The following is a description of a gene set: Abnormality of bone mineral density studied in species Homo sapiens This term applies to all changes in bone mineral density which (depending on severity) can be seen on x-rays as a change in density and or structure of the bone. Changes may affect all bones of the organism, just certain bones or only parts of bones and include decreased mineralisation as may be seen in osteoporosis or increased mineralisation and or ossification as in osteopetrosis, exostoses or any kind of atopic calicfications of different origin and distribution. The overall amount of mineralization of the bone-organ can be measured as the amount of matter per cubic centimeter of bones, usually measured by densitometry of the lumbar spine or hip. The measurements are usually reported as g/cm3 or as a Z-score (the number of standard deviations above or below the mean for the patient's age and sex). Note that measurement with this method does not reflect local changes in other bones, and as such might not be correct with regard the hole bone-organ. Human Gene Set: HP_ABNORMALITY_OF_BONE_MINERAL_DENSITY, and this is the list of marker genes: CDKN2B, AP1S2, NAE1, HBB, KCNJ8, CLCN5, NGLY1, GBA1, NFATC2, HAMP, AARS1, TMEM67, IRF5, OTX2, ATP7A, EHHADH, MPLKIP, SLC29A3, ADAMTS2 (ADAM metallopeptidase with thrombospondin type 1 motif 2), GLB1, SLC39A8, IL12RB1, BRAF, AMER1, MLXIPL, FANCD2, RFC2, IGF1, DNAJC21, NAB2, POLR3A, CHD6, LPIN2, SRP19, ALB, PCCA, NSD2, SMAD3, TSPAN12, PALB2, NPM1, TNPO3, PEX12, TNFSF11, DCHS1, IKBKG, EIF2AK3, CTCF, TET2, SNORD116-1, MEG3, CFTR, TRPV6, SPARC, NCF1, SOS1, MRPS22, ESR1, BUD23, HERC2, IL6, LACC1, MDM4, CYP27A1, LZTR1 (NCBI Gene Id 8216), PHEX, RRAS, INVS, RNU7-1, PRKACA, POLR1D, RNF113A, HHAT, LAMB3, GTF2H5, MITF, XYLT2 (NCBI Gene Id 64132), SOX3, DUSP6, FGFR1, CTC1, B3GALT6, FBN1, UBA2, HMOX1, TGFB1, NR0B1 (NCBI Gene Id 8238), FOXA2, CDKN2C, SFRP4, EED, PARN, MMP2, CEP164, TERC, TRPV4, AEBP1, MALT1, TRPS1, GK, SMS, FN1, LRP6, NPR2, HECW2, DDRGK1, TAPT1, FANCF, HGD, POLR1B, TMEM38B, MKRN3, CRIPT, TNFRSF11B, NPHP4, SPIB (NCBI Gene Id 6689), XRCC2, FGFR2, ELN, GNPTAB, STX3, CTDP1, PCCB, SRC, TBL2, COX4I2, SLC26A9, STAT1, SEC23A, PAPPA2, MIF, NPHP1, PTDSS1, CEP290 (NCBI Gene Id 9707), CBS, HLA-DRB1, PTH1R, NAA20, POU1F1, CYP11A1, CEACAM3, TMEM165, NOTCH3, MAP2K1, AXIN1 (NCBI Gene Id 8312), CBFB, GTF2IRD1, RPL10, BRIP1 (BRCA1 interacting helicase 1), HSPG2, LIMK1 (NCBI Gene Id 3984), FAM20C, AP2S1, DKK1, DHCR24, SMPD1, USP48, IFIH1, HRAS, FAM111A, HSD3B7, IQCB1, HSD17B4, SLC34A2, DNAJC30, CDKN1B (NCBI Gene Id 1027), RIN2, IL1RN, MEN1, NDP, SATB2, VCP, HLA-DQA1 (NCBI Gene Id 7946), SYK, PEPD, SEMA4D, PTEN, SOS2, LTBP4, SLC7A7, SPRED2, BANF1, CYP27B1, SETBP1, RBL2, IRX5, DLK1, PSTPIP1, GALT, RNF125, CLPB, WNK1, RASA2, PLEKHM1, TNFSF15, TNNC2, HFE, SMARCD2, HJV, TBCE, SH3PXD2B, POLG, COL1A2, POF1B, NHP2, CAVIN1, CTNNB1, PIGY, EDNRA, TJP2, WNK3, HNRNPH1, NR5A1, PLOD3, RFWD3, FANCE, CCDC141, LIFR, ACP5, VDR, SNRPN, CALCR, FKBP6, TAC3, FGF23, BRCA2, AVP, FSHR, NOP10, TYROBP, ZBTB20, SOST, ITGB4, NHLH2, TGFBR2, SDCCAG8, HTRA1, GATA1, HLA-DQB1, LMX1B, ANOS1, RPL11, MTRR, AIFM1, EBP, SLCO2A1, HGSNAT, MAGEL2, TMEM53, POC1A, WDR19, CREB3L1, B4GALT7, UBE2T, PLEC, CCN6, SCARB2, IFT52, DNA2, CYB5A (cytochrome b5 type A), GFI1, EXT2, NFIX, OSTM1, MAD2L2, PIGG, TREM2, SLC34A3, RIGI, BAAT, IFT56, CTSK, ASXL2, TONSL, ZEB2, SBDS (NCBI Gene Id 89877), RUNX1, MGAT2, SOX5, TCIRG1, DKC1, ESR2, TWNK, ENPP1, LRRK1, BMP15, TBCK, VPS37D, NDUFAF6, FGF17, OFD1, EFL1, FAH, FANCM, NUP107, HESX1, B3GAT3, MTX2, CARS1, OCA2, PPIB, PTPN11, SLC9A6, MAN2B1, ATP6V0A1, SLC17A5, AGXT, G6PC1, POLR3H, DMP1, GJA1, RRM2B, FLRT3, KDM1A, KISS1, FZD4, CSF1R, P4HB (prolyl 4-hydroxylase subunit beta), ERCC2, PDGFRB, KRAS, NDUFAF1, PROP1, GTF2IRD2, GCLC, NELFA, DBR1, AGK, CTBP1, MAFB, STAT6, HS6ST1, NDN (NCBI Gene Id 4692), PMM2, RIT1, OCRL, GNA11, COL2A1, BMS1, SMARCAL1, DPM2, FEZF1, CA2, FANCG, UFSP2, ATP7B, TBXAS1, IER3IP1, RAB3GAP1, STX1A, TCF12, LAMA3, FBXO11, FKBP14, BMP4, GTF2E2, MBTPS2, MTTP, ARL6IP6 (ADP ribosylation factor like GTPase 6 interacting protein 6), WRN, FARSB, MIA3, NPAP1, MED12, DLX3, SRCAP, PDLIM4 (PDZ and LIM domain 4), LETM1, FBN2, RTL1, COPB2, FLNA, STN1, GORAB, SP7, KNSTRN, SLC4A2, TNFRSF11A, TENT5A, LRP4, ATRX, NRAS, ZFX, NAGLU, IL12A, ALK, LHX4, CYP2R1, WRAP53, SGSH, SQSTM1, ADCY10, MMEL1 (NCBI Gene Id 79258), GLA, SGMS2, SLC4A1, WT1, LAMA5, CDKN1C, SLC39A14 (solute carrier family 39 member 14), POU2AF1, ZNF699, NOTCH2, BAZ1B, SCN9A, SKI, KDELR2, GSTM3, ABCC9, STAT3, LEMD3, CLDN16, TRMT10A, LMNA (lamin A/C), LRP5, SLC2A2, WDR35 (NCBI Gene Id 57539), MMP13 (matrix metallopeptidase 13), MAP3K7, GEMIN4, SIM1, ERCC8, CBL, PUM1, SLC25A4, FANCA (FA complementation group A), SLX4, ABCC6, CANT1, SPRY4, SOX9, SLC6A14, LEMD2, AFF3, ZMPSTE24, GET4, CHD7, PRKAR1A, SLC9A3, VPS53, CLIP2, SIK3, SLC37A4, TYMS, DDOST, PROK2, PYGL, POLD1, FERMT3, SLC12A1, SEC24D, NLRP3, ANTXR2, MRAS, DCC, LBR, SEMA5A, COL5A1, CLCA4, UNC80, RTEL1, CDH23, SRSF2, HMGA2, COL1A1, CASR, MST1, SCN4A, SERPINA1, SPIDR, ERCC6, NDNF, GCM2, FANCL, CCDC134, IFT140, MTAP, STX16, WNT3A, ADAMTSL2, BMP6, PRLR, P3H1, SLC39A13, ALG3, ARMC5 (armadillo repeat containing 5), ALDH18A1, GLIS3, BRCA1, KCNJ1, CDC73, DHX37, ATP6V0A2, SLC35A2, POLR1C, BNC1, MAP3K1, FANCB (NCBI Gene Id 2187), ZNF408, SLC10A1, FKBP10, HPGD, DCTN4, RNU4ATAC, RNU4-2, DPAGT1, CYP19A1, KARS1, PLOD1, PDE11A, SLC34A1 (solute carrier family 34 member 1), AIP, SEMA3E, CEACAM6, NAF1, AKR1D1, SLC25A19, KL, PROKR2, CYP17A1, IARS2, RECQL4, SC5D, GNRH1, ATP8B1 (ATPase phospholipid transporting 8B1), SEMA3A, POLG2, CCND1, MBTPS1, LAMC2 (NCBI Gene Id 3918), IL17RD, PYCR1, NFKBIA, WNT1, MMP14, MMP1, GNRHR, GNAS, IFT43, RAD51C, ASAH1, FXN, ALPL, SLC11A1, RAD51, ZNF668, ERCC3, SOX10, TERT, KIF1A, CYP3A4, PIK3CD, NAGA, SNORD115-1, RAF1, NHERF1, TRAF3IP1, ERI1, TRAPPC2, GALNS, KIT, RRAS2, FANCI, TINF2, RSPRY1, TCF4, ASCC3, PLOD2, PSAP, FUT8, METTL27, NPHP3, NF1, UROD, HNRNPK, POLRMT, SRY, SNX10, PWRN1, FAT4, USP8, MC4R, GPR35, IFITM5, COL7A1, PIGT, PRG4, TARS1, ZSWIM7, GTF2I (general transcription factor IIi), PHKG2, USP9X, BMP2, ANO5, SERPINH1, PSMC3IP, BMP1, CRTAP, DLL4, HNF4A (hepatocyte nuclear factor 4 alpha), PHLDB1, DVL1, NR3C1, COG1, CHST3, NSMF, MSH4, UNC45A, CPLX1, RUNX2, PHKB, TACR3, GNPAT, COL5A2, VAMP7, FANCC, CDKN1A, CLCN7, SPRTN, RETREG1, WDR11, ASXL1, POLE, ATP6V0A4, ERCC4, PIGU, EIF4H, TMEM270, CTNND2, TP53, TRIP11, UROS, LARS2, PRDM5, FBLN5, KCNN4, FGF8, GATM, PHKA2, CTNS, ELANE, GLI2, GATA4, ANAPC1, USB1, ZNF469, TAF1, PWAR1, ZFPM2, GPAA1 (glycosylphosphatidylinositol anchor attachment 1), SLC26A2, WWOX, IFT122, KISS1R, TCOF1, ANKH